Given this list of marker genes YKT6, SLC39A6, YJU2, TBCB, GPR35, PSMD3, NLRP3, NR2F6, SF1, QPCT, PTPN9, CCL8, ADAM15, PKD2, MARCHF6, CCL3, TBC1D22A, LEF1, H2AC16, LRRFIP1, MTCL1, VCAM1, PRPF40A, CALCRL, EZH2, BIRC3, UQCRC1, ALAS1, AKR1B1, VEGFA, IGHE, SLC5A2, SULT4A1, TUBA1B, STK4, IRF5, ZNF804A, RRP1B, LY75, H6PD, FBXO7, DLGAP4, CBR3, KIF2A (NCBI Gene Id 3796), PCCB, RELB, FKBP1B, MVP, TNFRSF11A, ADAM19, GTF2A2, PRKCD, TIMP3, DEGS1, NFX1, GSTP1, LAMP3, CLTB, TLN2, IL10RA, CSNK2B, CDC34, CAMK1G, CST7, H3C11, SLC7A1, CD200, TXN, KCNA3, RHOQ, LYPD3, DICER1, MKNK2, PAX9, UCP2, VCP, NCK2, SCARF1, HBEGF, RAB4B, PPP6R1, MOK, CSTF2, CLIC2, DPY19L1, IL1R1, PIM2, GTPBP1, STARD3, CAMTA2, LTA, CDS2, NMI, MC2R, CYB5R3, CD83, TP53I11, LILRB4, CASP7, SYNGR2, MDH1, ANPEP, MSMB, ACOT13 (NCBI Gene Id 55856), AP1G1, MYCL, SEL1L3, GP1BA, SDF2, BLTP2, BCAR3, CCNH, SLC7A4, CTSC, MTX1, CAPNS1, MRPL28, PPP1R7 (protein phosphatase 1 regulatory subunit 7), NDUFV2, CH25H, EPHX1, EGFR, RAMP1, RBMS2, HNRNPM, CTSZ, GSE1, DHX16, LITAF, ZNF44, PMP22, RBBP8, PEPD (peptidase D), ETFA, KPNA2 (NCBI Gene Id 728860), MAPKAPK3, ZNF510, CCL22, DNASE1L3, IL7R, C2, FAM131B, FOXN3, IQSEC1, VPS72, GH1 (NCBI Gene Id 2688), AHCY (NCBI Gene Id 191), RAB11B (RAB11B, member RAS oncogene family), MISP, TDG, DAXX, BAAT, ACADVL, PPFIBP2, RABEPK, HLA-DQA1, SELP, NPIPB15, ZNF76, TIMM44, ATP6V1G1, CKB, CFLAR, CD86, HMGN3, WIZ, UBE2S, MMP12, RECQL5, TELO2, MRPL9, ABCC3, CLSTN1, CA2, SMYD5, FXR2, CDH5, ANGPT1, PALLD, HS3ST1, SS18L1, CCL11, NFKBIA, CYP2A6, CSF2RB, TRAF4, HOXC6 (NCBI Gene Id 3223), CRH, PDGFA, DIAPH1 (diaphanous related formin 1), TUBA3D, MAP2K6, PTPRE, TRAF3IP3, GRB2, GAK, CASP3, SRP14, RNF115, GPR37L1 (G protein-coupled receptor 37 like 1), here is a description of the gene set: Human Gene Set: GSE360_DC_VS_MAC_L_DONOVANI_UP Monocyte-derived dendritic cells (DC) and macrophages (MΦ) generated in vitro from the same individual blood donors were exposed to five different pathogens, and gene expression profiles were assessed by microarray analysis. Responses to Mycobacterium tuberculosis and to phylogenetically distinct protozoan (Leishmania major, L. donovani, Toxoplasma gondii) and helminth (Brugia malayi) parasites were examined, each of which produces chronic infections in humans yet vary considerably in the nature of the immune responses they trigger. from publication Chaussabel D, Semnani RT, McDowell MA, Sacks D, Sher A, Nutman TB (PMID 12663451) Genes up-regulated in comparison of dendritic cells (DC) exposed to L. donovani versus macrophages exposed to L. donovani. studied in species Homo sapiens